Given this list of marker genes ERCC4, TOP3A, ERCC5, NABP2, WDR48, NUCKS1, IGHM, ERCC1, RAD18, SMARCAL1, POT1, MAPT, MCM2, WBP11, MSH2, PCBP3, PARK7, HROB, PCBP2, SWSAP1, RECQL4, TSN, SUB1, DHX36, RECQL, TERF1, MCM8, DHX9, PURA, APTX, CDC45, FUBP1, RAD51AP1, HNRNPU, SPRTN, HMCES, RTF1, SMARCA1, POLR2G, DMC1, BLM, TDP1, LONP1, TOP1, RBMS1, HMGB1, RPA1, MLH1, DDX11, MCM7, MCM3, FUBP3, TERF2IP, SMC6, JCHAIN, YBX1, PCBP1, RADX, MCM6, HMGB2, BIVM, MCM5, TDP2, RAD51B (NCBI Gene Id 5890), CTC1, TWNK, MCM10, RAD50, RNF138, RPA4, POLR2H, MCM4, NEIL3, PMS2, FAM111A, SHOC1, BRCA2, POLA1, RAD52, RAD23A, ZRANB3, PURB, HSF1, SSBP3, LRPPRC, NOL12, TREX1, MEIOB, TEN1, FBH1, SMC5, REXO4, HNRNPDL, MSH3 (mutS homolog 3), RAD51, STN1, IGHMBP2, TP53, SMC2, SMC4, C19orf33, MMS22L, RPA2, MCM9, SSBP4 (NCBI Gene Id 84713, single stranded DNA binding protein 4), RAD23B, CRY2, HNRNPA2B1 (heterogeneous nuclear ribonucleoprotein A2/B1), TERF2, HNRNPA1, RPA3, POLR3C, SETMAR, XPC, RAD51D, HSPD1, RAD54L, NABP1, POU4F1, SSBP1, SSBP2, TSNAX, SAMHD1, here is a description of the gene set: Human Gene Set: GOMF_SINGLE_STRANDED_DNA_BINDING Binding to single-stranded DNA. studied in species Homo sapiens